Given this list of marker genes Cntnap4, Cnr2, Mir26a-2, Slc24a2, S100b, Slc7a11, Pde4a, Nrxn3, Ica1, Prkcg, Lrrtm2, Ssh1, Rin1, Rtn4, Neurod2, Large1, Mir24-2, Dlgap3, Nrxn1, Adnp, Syt8, Nefl, Mir100, Mir467a-7, Zdhhc2, Mctp1, Grm8, Mirlet7f-1, Adcy1, Tnf, Grid2ip, Acp4, Arhgap44, Arc, Calhm2, Creb1, Jph4, Ube3a (ubiquitin protein ligase E3A), Pde9a, Adgrb1, Chat, Mir218-2, Drd4, Htr1d (5-hydroxytryptamine (serotonin) receptor 1D), Drd1, Nr2e1, P2rx1, Mir384, Nf1, Chrna3, Eif4a3l2, Hcrt, Mapk3, Wnt7a, Ptpn5, Mir467a-5, Edn1, Kras, Chrm2, Sipa1l1, Shank2, Mapk1, Gria4, Star, Lrrk2, Prnp, Nsg1, Cd38, Cplx3, Cacng5, Slc12a2, Stau1, Pla2g6, Atad1, Grin3a, Dgki, Cpeb1, Clstn2, Mir149, Tyrobp, Tacr2 (NCBI Gene Id 21337), 2610042L04Rik, Fyn, Nxph4, Cln3 (CLN3 lysosomal/endosomal transmembrane protein, battenin), Mapk8ip2, Penk, Btbd9, Camk2g, Mir770, Arrb2, Mir467b, Chmp2b, Atp1a3, Mir328, Mir125a, Adra2a, Bcr, Drd5, Mapk9, Mir148b, Cacnb3, Sorcs2, Itpka, Gria2, Mylk2, Chrnb3, Nrn1, Tshz3, Ptk2b, Cpeb3, App, F2r, Dvl1, Ngdn, Cacna1a, Mir501, Shank1, Bsn, Adrb2, Htt, Shisa8, Dgkb, Rasgrf1, Baiap2, Mir181c, Mir467a-1, Mir673, Stxbp1, Ccl2, Mir106b, Nfatc4, Sorcs3, Lgi1, Vgf, Cntnap2, Vps13a, Mir23a, Dlgap2, Snca, Cnrip1, Ube2i, Lrrtm1 (NCBI Gene Id 74342), Plcl2, Mir383, Cc2d1a, Map1a, Mir137 (microRNA 137), Mpp2, Neo1, Prepl, Zdhhc17, Pcdh17, Nlgn2, Mir138-2, Mir345, Ager, Clstn1, Tac1, Ophn1, Neurl1a, Zmynd8, Akap7, Stx4a (NCBI Gene Id 20909), Apba2, Kcnc3, Gnao1, Stat3, Mir425, Dlg4, Npy2r, Mir181a-1, Rnf167, Asic1, Adora2a, Cnr1, Clstn3, Mir484, Kcnj10, Prkcz, Afdn, Kat2a, Egr1, Fbxl20, Mir29a, Ppp1r9a, Lama2 (laminin, alpha 2), Mapt, Begain, Ptger4, Cacna1d, Mir153, Mir19b-1, Best1, Akap5, Ntng2, Slc6a1, Kdr, Nog, Mir15a, Mir330, Mir218-1, Syt13, Mir421, Rapsn, Mir338, Sh3gl1, Stx3, Mir551b, Igsf21, Slc6a4, Mir7b, L1cam, Ythdf1, Cacna1b (calcium channel, voltage-dependent, N type, alpha 1B subunit), Plk2, Nps, Sv2b, Itgb1, Mir92b, Vps35, Chrm1, Sctr, Cplx2 (complexin 2), Htr1b, Cacna1e, Gabrr1 (gamma-aminobutyric acid type A receptor subunit rho 1), Cpeb2 (cytoplasmic polyadenylation element binding protein 2), Mir150, Mir26b, Nptn, Ucn, Dtnbp1, Cacng8, Mir195a (microRNA 195a), Mir433, Rapgef4, Braf, Chrna7, Camk2d, Unc13b, Rims3, Htr1a, Nos1, Sct, Myo6, Gabbr1, Pmch, P2rx2 (purinergic receptor P2X, ligand-gated ion channel, 2), Drd3, Eif2ak4, Gfap, Cacng3 (NCBI Gene Id 54376), Cfl1, Lrrc4c, Stxbp5, Crh, Mir410, Mgll, Tmem25, Stx1a, Grik1, Slitrk5, Mir872, Prkar2b, Dlgap4, Npy1r, Mir92-2, Ifng, Pak1, Mir467a-8, Dag1, Psen1 (presenilin 1), Serpine2, Ncan, Ggcx, Ptpra, Gipc1, Chrdl1, Cplx4, Mir151, Fxr1, Cacna2d2, Mir300, Abhd6, Fam107a, Tent2, Rab8a, Nlgn4l, Grin2c, Jph3, Mir29b-1, Slc4a10, Mir467a-3, Slc38a2, Mir101b, Kcnb1, Dbn1, Calb1, Mir25, Mir467a-10, Plg, Mctp2, Pten, Syde1, Pclo, Mir204, Npy5r (NCBI Gene Id 234339), Cd2ap, Htr2a, Ace, Mir1983, Snapin, Cx3cr1, Jak2, Ntrk2, Lypd6, Prkn, Mir467a-4, Kcnk2, Abr, Prkar1b, Igsf8, Mir92-1, Lnpep, Kmo, Nmu, Git2, Rgs4, Uts2, Mir487b, Cbln2, Mir9-2, Agrn, Ghsr, Dnm1, Flot1, Rnf19a, Gnai1, Rara, P2rx3, Ptk2, Sybu, Rims1 (NCBI Gene Id 77473), Mir130a, Rasgrf2, Mir187, Syn1, Lzts1, Nrgn, Nlgn1, Ncs1, Egfr, Reln, Lgmn, Kcnh1, Pate4, Car2, Wnt3a, Mir486, Sncg, Camk2b, Kif5b, Syt12, Mir337 (microRNA 337), Mir26a-1, Nrg3, Cbln1, Stxbp5l, Tprg1l, Hap1 (NCBI Gene Id 268486), Mir125b-2, Tmem108, Slc6a9, Rab3gap1 (NCBI Gene Id 69346), Mir127, Hdac6, Synpr, Grm7, Mir369, Glra2, Epha7, Ntf3, Grik3, Grk2, Mir126a, Mir379, Chrna2, Ngf, Erbb4, Ccr2, Cacng2, Mir378a, Slc24a1, Syngap1, Agt, Slitrk4, Ephb2, Oxtr, Cacng7, Grm3, Homer1, Igf1, Mme, Mir744, Mir211, Adcy8, Dgke, Kctd13, Retn, Grid2, Cyfip1, Mir382, P2ry2, Syt5, Glra3, Mir9-1, Adipoq, Slc30a1, Mir98, Disc1, Rab11a, Ppfia3, Adora3, Prkar2a, Sv2c, Kiss1r, Ptn, Mir99a, Zdhhc3, Mir145a, Atp2b2, Dnm1l, Mir134, Tspoap1, Mir434, Ptgs2, Pirb, Syt4, Mir500, Iqsec1, Cdkl5, Mir7-1, Htr6, Spg11, Rac1, Grm2, Mir672, Akap12, Clmp, 2510002D24Rik, Mirlet7i, Atf4, Arf1, Ncstn, Grid1, Car7 (carbonic anhydrase 7), Cdh2 (cadherin 2), Kit (NCBI Gene Id 16590), Grin3b, Vps18, Phf24, Mtmr2, Shisa6, Chrna4, Plat, Mir30c-1, Trio (triple functional domain (PTPRF interacting)), Grm5, Mir29b-2, Nxph1, Rhot1, Enpp1, Grik5, Cspg5, Mir301b, Mir181b-2, Eif4e, Mir7-2, Mir30c-2, Pfn1, Mir28a, Frrs1l, Nalcn, Mir222, Mir19b-2, Mir106a, Slc4a8, Camk2a, Kcnq2, Cdc20, Zdhhc12, Cdh11, Mir23b (NCBI Gene Id 387217), Lrrc4, Mir125b-1, Ywhag, Htr2c, Mir411, Mir320, Cask, Lrfn2, Grip2 (glutamate receptor interacting protein 2), Rims2, Mirlet7d, Egr2, Fgf14, Mir221, Npy, Hip1, Ina, Gip, Bglap2 (NCBI Gene Id 12097), Tacr1, Mir667, Pxk (NCBI Gene Id 52518), Mir129-1 (NCBI Gene Id 387237), Syp, Pcdh8, Ntng1, Cacng4, Mir138-1, Mir674 (microRNA 674), Myo5a, Igsf11, Grm1, Shisa9, Rab3a, Gucy1a1, Stx1b, Fbxo45, Lrp8, Hrh1, Gpr158, Cdh1, Slc8a3, Cdk5, Mir467a-9, Mir24-1, Syt2, Plcb1, Mir467a-6, Apba1, Map1b, Nefh, Pfn2, Plppr4, Synpo, Mir652, Ntf5, Brsk1, Abl1, Nisch, Mmp9, Ror2 (receptor tyrosine kinase-like orphan receptor 2), S1pr2, Homer3, Wnk1, Adora1, Pafah1b1, Syap1, Grm4, Ntrk1, Fabp5, Slc1a1, Wnt5a, Usp46 (ubiquitin specific peptidase 46), Nlgn3, Mir30d, Pink1, Fbxo2, Rab5a, Drd2, Grip1, Mir539, Mir124-2hg, Mir342, Chrd, Fcgr2b, Prrt2, Musk, Ncdn, Tubb2b, Rap1a, Crhr2 (corticotropin releasing hormone receptor 2), Epha4, Mecp2, Fxr2, Mir93, Grik4, Mir381, Gria3, Zzef1, Syt1, Gpr151, Chrna6, Cyp46a1, Sncaip, Rgs14, Ppp3r1, Eif4ebp2, Mir9-3, Prkca, Mir19a, Mirlet7c-2, Igf1r, Bglap, Camk4, Unc13c, Prkce, Pacsin2, Ckap5, Eif4a3, Ctnnd2, Myo5b, Dlgap1, Gnal, Sqstm1, Oprm1, Grik2, P2ry1, Mir132, Dkk1, Usp8, Kcnq4, Celf4, Prrt1, Ngfr, Pate6, Slc8a2, Bcl2l1, Git1, Ghrl, Psmc5, Kmt2a, Dmpk, Snap29, Cntn2 (NCBI Gene Id 320300), Stau2, Cbln4, Dbi, Grin2d, Slc6a6, Gsk3b, Mirlet7c-1, Ywhah, Nr3c2, Mir101a, Anapc2, Ephb1, Alg13, Unc13a, Snx14, Grin2b, Cplx1, Htr7, Prkcb, Slc18a3, Nsmf, Neto1 (NCBI Gene Id 246317), Mir30b, Mir20a, Oxt, Gnai2 (NCBI Gene Id 97505), Mef2c, Ptprs, Notch1, Glul, Efnb3, Crhr1, Nr3c1, Mir22, Chrna5, Cckbr, Mir324, Adra1a, Edn3, Plcb4, Hnrnpk, Atp2a2, Fmr1, Nedd4, Psen2, Slc7a10, P2rx7, Mir181d, Prkaca, Crtc1, Mir540, Gsg1l (GSG1-like), Chrnb2, Mir128-2, Itpr3, Mir128-1, Bace1, Ptprd, Lamp5, Baiap3 (BAI1-associated protein 3), Mdm2, Mir191 (microRNA 191), Dcc, Grin2a, Grm6, Snap25, Mir129-2, Rapgef2, Slc1a3, Hras, Pick1, Mir17, Srf, Mirlet7f-2, Syt7, Rap1b, Cacnb4, Bdnf, Cyth1, Paip2, Neto2, Ncam1, Adora2b, Tbc1d24, Mir181b-1, Adrb1, Plcg1, P2ry4, Shisa7, Mir30e, Iqsec2, Mir124a-1hg, Faah, Mir760, Kcnq3, Bche, Apoe, Vamp2, Shank3, Micu3, Syngr1, Npas4, Mapk8, Atg5, Camkv, Gper1, Mirlet7e (NCBI Gene Id 387248), Pnkd, Mir541, Gria1, Rps6kb1, Mtor, Slc38a1, Mir181a-2, Mir467a-2, Hmgcr, Eif4a3l1 (NCBI Gene Id 671719), Mir374b, Ppp3ca, Nrxn2, Kiss1 (NCBI Gene Id 280287), Rims4, Ppfia2, Sphk1, Il1b, Hrh2, Cux2, Mir30a (microRNA 30a), Snap47, Plcl1, Kcnn2, Kcnc4, Adcyap1 (adenylate cyclase activating polypeptide 1), Grin1, Met, Tnr, here is a description of the gene set: species: Mus musculus Mouse Gene Set: GOBP_REGULATION_OF_TRANS_SYNAPTIC_SIGNALING Any process that modulates the frequency, rate or extent of trans-synaptic signaling.